Given this list of marker genes Loxl2, Loxl1, Tll2 (NCBI Gene Id 24087), Loxl4, Loxl3, Lox, Col4a2 (collagen, type IV, alpha 2), Col4a5, Col4a6, Bmp1, Pcolce, here is a description of the gene set: This event has been computationally inferred from an event that has been demonstrated in another species.<p>The inference is based on the homology mapping from PANTHER. Briefly, reactions for which all involved PhysicalEntities (in input, output and catalyst) have a mapped orthologue/paralogue (for complexes at least 75% of components must have a mapping) are inferred to the other species. studied in species Mus musculus Reactome Pathway: Crosslinking of collagen fibrils part of: Assembly of collagen fibrils and other multimeric structures electronically inferred by orthology from the curated human pathway